The following is a description of a gene set: from publication Szanto A, Balint BL, Nagy ZS, Barta E, Dezso B, Pap A, Szeles L, Poliska S, Oros M, Evans RM, Barak Y, Schwabe J, Nagy L (PMID 21093321) Genes down-regulated in wildtype bone marrow-derived macrophages: control versus treated with rosiglitazone. Conditional macrophage-specific PPARg knockout mice were generated on C57Bl/6 background by breeding PPARg fl/- (one allele is floxed, the other is null) and lysozyme Cre transgenic mice. PPARg and IL-4 signaling was analyzed on bone marrow-derived macrophages. Bone marrow of 3 mice per group was isolated and differentiated to macrophages with M-CSF (20 ng/ml). 20 ng/ml IL-4 was used to induce alternative macrophage activation and 1 uM Rosiglitazone (RSG) was used to activate PPARg. From each mouse 4 samples were generated: 1. M-CSF, 2. M-CSF+RSG, 3. IL-4 and 4. IL-4+RSG. All compounds were added throughout the whole differentiation process, and fresh media was added every other day. Control cells were treated with vehicle (DMSO:ethanol). After 10 days, RNA was isolated and gene expression profiles were analyzed using Mouse Genome 430 2.0 microarrays from Affymetrix. studied in species Homo sapiens Human Gene Set: GSE25123_CTRL_VS_ROSIGLITAZONE_STIM_MACROPHAGE_DN, and this is the list of marker genes: CES5A, POLR3K, RYR3, LAMTOR3, MRPL20, CD300LF, GNPDA2, SMIM15 (NCBI Gene Id 649861), FRMPD3, PSME4, ACP1, SPMAP2L, ENPP3, GMFG, IYD, SRP54, SNRNP48, GABRA5, SVBP, PREX2, IL18RAP, COLGALT2, CHRNA6, FCGR2A, CD248, CCDC127, ZNF638, OR51E1, ADCY1, NANP, NHLRC2, UNC5C, NMNAT1, NIPBL, COPRS, MRPS18C, TTC9C, PTPRC, SNIP1, GMNN, MED30, LUM, CD302, WDR54, RBFOX2, WDR3, SEC16B, NDUFB3 (NCBI Gene Id 4709), WNT1, RNF222, ECT2, NASP, EIF3E, UGT3A2, GAS2L3, MRPS9, FAM120C, BTBD1, MIR1915HG, NFKBIA, HPF1, EPRS1, SOX21, EIF3H, SIRPB1 (signal regulatory protein beta 1), MRPS31, TMTC2, SLIRP, ZC2HC1C, RPP30, DACH1, TRPC1, RPF2, APPL1, GPC6, LNX1, KIF24, TMEM181, OR51B2, GOLGA7B, SEC61B, CYFIP1, FANCL (NCBI Gene Id 55120), NCAPH (NCBI Gene Id 679), YIPF7, KIF18A, NOVA1, NRN1, NOCT, TMEM70 (transmembrane protein 70), MRPS33, UQCR10, CENPU, AAK1, COX6C, RIF1, SAPCD2, STAG2, CREB1, SDC2, PLEKHH1, PPP1CC, DYNLT1, CAST, DRAM1, ELOVL1, SMC2, HTRA3, TLR5, ZNF8, SKIC8 (NCBI Gene Id 80349), SNCB, SLC34A2, MORF4L1, LYVE1, CTSE, HYKK, GEMIN6, COL4A4, FMO1, MAGI3, BAALC, PLK4, RBM45, TMEM128, HPRT1, PRAMEF25, DBH (dopamine beta-hydroxylase), CSNK1D, CWC22, NRP2, TAL1 (TAL bHLH transcription factor 1, erythroid differentiation factor), SLC30A4, C5orf47, LAPTM5, SWT1, AKR1B1, CGA, GTF2H5, ZNF280D, PGK1, ZNHIT3, PAX3, CEP55, BOK, KYNU, S1PR2, SNX7 (sorting nexin 7), MRPL42, URGCP, INSL5, NDUFA2, FAM161A, RBBP7, TPP2, NUDCD1, RNPS1, LORICRIN, NMD3, WASHC2A, AGFG2, PCDHB5, KRT80, PSMA5 (NCBI Gene Id 5686), AHNAK2, PBDC1, CAMLG, FAM72A, MAD2L1, MAN2A1, ANKRD24, PLA2G4D, NDUFA12 (NADH:ubiquinone oxidoreductase subunit A12), LMO3, EPN2, KY, RAN, TTC33, BNIP3L, OSCAR, NXPH3, IDH3A, STARD6, TRIQK, APH1B, C5orf46 (NCBI Gene Id 389336), KIF26A, SPCS3, PRSS42P, TM9SF2, DDX54, GREB1L, TTC1, FRY, VGLL2, FGL1, PSMA2, RTRAF, VPS35, IMPG1